Given this list of marker genes OR10W1, EIF5, KPNB1, MAGEL2, FOXO1, AEBP2, GCNT1, USP45, TARBP1, SERINC5, EPHA3, ZFHX4, RICTOR, AP3S1, KRAS, ERLIN1, DNAAF9, PHAF1, FAM171A1, NOVA1, RAB2A, SPIN1, ZHX1, FEM1B, RALGPS1 (Ral GEF with PH domain and SH3 binding motif 1), PLAGL1 (PLAG1 like zinc finger 1), HSPA2, AK3, PPM1F, PNPLA1, STK19, GLE1, STMND1, QKI, ITPR2, NOVA2, CNTN1, SINHCAF, LRIG1, CHIC1, HOXA9, LRRC3, ARPC5L, ARHGEF12, CRKL, JPT2 (NCBI Gene Id 90861), USP5, MED14, FOXK2, CYRIB, SNX30, USF3, TBR1, PAIP1, NUS1, PDZD8, FKBP7 (NCBI Gene Id 51661), APPL1, PPP1R9B, NRN1, ABCA2 (ATP binding cassette subfamily A member 2), RWDD4, NCKAP1, ASH1L, TRIB3, GRB2, CPSF6, MSN, DLEU7, PHACTR4, ABCD1, EDEM1, EOMES, HDAC7, FGF9, EIF4EBP2, TTYH3, MFAP3L, DOCK4, DOCK9, PIK3C2A, RELL1, ZFC3H1, CORO1C, RAB23, CTTN, MAP3K3, RAB3C, CTDSP1, BRMS1L, ATXN1, ZCCHC3, MTCL2, ITPR1, BRINP2, ANKRD27, FRS2, AHR, PALLD, MRAS, AQP2, BCL2L12, POU2F2, CACNA2D2, PLOD2, CHST1, E2F5, ST7, SLAIN2, SEPTIN9, LMTK2, DDAH1, ARHGAP6, MYRIP, PRIMA1, DAAM1, MTDH, DOCK1, PHIP, SPEN, ELOVL5, DPY19L3, PRKCE, BCR, B4GALNT1, SESN3 (sestrin 3), KCNK9 (potassium two pore domain channel subfamily K member 9), ARPP19, SLC44A2, HAS2, ZDHHC17, NUDT13, RAB10, RIOX1, PLCB4, LNX2, PPM1L, ELAVL4, OGT, EBF3, MIGA1, FN1, IGF2BP1, ALK, SNX16, THBS2, OSBPL10, TOPORS, ZHX2, NEXMIF, TAF4B, FNDC3B, C5orf22, OVOL1, FYCO1, TUT4, IRS1, PCGF5 (polycomb group ring finger 5), LPP (NCBI Gene Id 4026), PAFAH1B1 (NCBI Gene Id 5048), CAV1, TOX, SORT1, ADK, ANKIB1, ZEB1, LMTK3, EIF3J, AZIN1, KIAA0513, CD164, SLC7A8, RGS17, PHYHIPL, SPAST, ADGRL2, DCUN1D3, SCML4, RNF139, MORF4L1, KIAA1217, ATP2B4, CBFA2T3, PDE8B, SLC12A6, IGF1R, ZCCHC14, CERS2, RAB27A, SLC6A9, ACTRT3, PAK1, SIN3B, ZFP36L1, HBEGF, ABHD13, LRRC7, LRRC28, BRPF3, TMEM169, LHX1, SLC38A4, GPC3, SLC39A1, EVI5, KLHL7, KLHL4, ST6GALNAC3, PPIL1, SERPINB2, CADM2, GXYLT1, TMEM198, LRRC4, RBM20, GPR135, ZNF704, DHX8, ATXN3, B3GNT2, CHST10, FRMD5, LILRA1, WDR82, NANOS1, LAMC1, SPSB1, PDZRN4, GBP5 (guanylate binding protein 5), LRCH2, SEZ6L (seizure related 6 homolog like), TRIM46, RGPD1, SH3PXD2B, MED1, CACNB4, ANXA11 (annexin A11), MAP1B, UBE2Q2, SOX5, MFAP3, FOXF2, FOXQ1, YES1, SLC24A4, ASTN1, SH3KBP1, PPP4R3A, VAT1L, REV1, OLFM1, SH3BP5, MTHFD2L, PRRG3, YWHAG, BNC2, AGO4, STAG1, TAC1, RUNDC3B, ERC2, CNOT6L, MAP2K3, KLHL34, ARHGEF3, PYGO2, UCK2, CLN5, SLC33A1, GALNT2, RITA1, PHF20L1, MROH2A, ADGRB3, TRIM9, FADS1, PGAP1, RAB8B, VAMP3, CNN3, MAP2K1, SDC2, SMAD1, SPAG8, HOOK3, ADCY6, PURA, PRTG, PRDM16, JMJD1C, PRKAR1A, ZFAND5, MTOR, RARG, NEK7, FAM43A, YIPF4, STX5, RASSF8, PPP3CA, CELSR2, KCNG3, COL25A1, EPAS1 (NCBI Gene Id 2034), GNAI3, CNNM3, EXT1, REPS2, DMXL1, GDNF, DEUP1, OXSR1, NLGN2, CDH20, COL13A1, TAPT1, DCUN1D1, GAP43 (NCBI Gene Id 2596), UNC13C, PTP4A1, RPS6KA6, GAN, MTSS1, XKR4, SOX6, CREB3L2, STK17B, SLITRK4, TCF7L2, MORF4L2, OXGR1, TMEM170B, BRWD3, ATG9A, MITF, TPR, SYT16, ZBTB41, STK17A, PTGER3, SLC1A1, FOXO3, SCYL3, NCALD, RALB, PLPPR4, RNF183, SLC44A5, MAP3K2, PRRT3 (proline rich transmembrane protein 3), CRYGS, VAT1, SPRY3, BICRAL, DLAT (NCBI Gene Id 1737), SLC39A9, DEPTOR, GPR22, LCP1, GIT2, FZD3, SV2C, TNS3, PRRX1, RGS2, SLC26A9, SLC16A9, SLF2, PPP3R1, AJAP1, SLC22A5, RAPGEF4, NEUROD4, NPTX2, SLC12A5 (NCBI Gene Id 57468), DPYD, L1CAM, WIPI2, MCMBP, ERG, FARP1, PTPMT1, MAST4, CEP170B, MAK, LGI1, NTN4, UBE2G1, here is a description of the gene set: from publication Chen Y, Wang X (PMID 31504780) Human Gene Set: MIR12133 studied in species Homo sapiens Genes predicted to be targets of miRBase v22 microRNA hsa-miR-12133 in miRDB v6.0 with MirTarget v4 prediction scores > 80 (high confidence targets).